The following is a description of a gene set: studied in species Homo sapiens Human Gene Set: GOMF_OXIDOREDUCTASE_ACTIVITY_ACTING_ON_PAIRED_DONORS_WITH_INCORPORATION_OR_REDUCTION_OF_MOLECULAR_OXYGEN_REDUCED_PTERIDINE_AS_ONE_DONOR_AND_INCORPORATION_OF_ONE_ATOM_OF_OXYGEN Catalysis of an oxidation-reduction (redox) reaction in which hydrogen or electrons are transferred from reduced pteridine and one other donor, and one atom of oxygen is incorporated into one donor., and this is the list of marker genes: TH, TPH1, PARK7, PCBD1, PAH, AGMO, TPH2